Given this list of marker genes HCCS, COX7B, NDUFB11, MAN2C1, CAPRIN1, here is a description of the gene set: Discontinuity in the convexity of the inferior margin of the lobe. Human Gene Set: HP_CLEFT_EARLOBE species: Homo sapiens Cleft earlobe